Given this list of marker genes PLA2G12A, MBOAT1, PLA2G4D, PLA2G1B, PLA1A, PLA2G5, PLA2G2A, OSBPL10, OSBPL5, PLA2G2D, OSBPL8, PLAAT3, PLA2G4F, LPCAT3, PLA2R1 (NCBI Gene Id 22925), LPCAT4, PLA2G2E, PLA2G4B, PLA2G2F, PLA2G4E, PLA2G4A, PLA2G10, here is a description of the gene set: Acyl chain remodelling of PS species: Homo sapiens Human Gene Set: REACTOME_ACYL_CHAIN_REMODELLING_OF_PS